The following is a description of a gene set: Human Gene Set: MIR296_3P species: Homo sapiens from publication Chen Y, Wang X (PMID 31504780) Genes predicted to be targets of miRBase v22 microRNA hsa-miR-296-3p in miRDB v6.0 with MirTarget v4 prediction scores > 80 (high confidence targets)., and this is the list of marker genes: ATP5MG, C1QTNF7, GOLGA6L10, TRPC5, AZI2, ABLIM3, ZNF28, TOMM70, ZNF493, EXPH5, PFN2, ZNF124, SLITRK2, ZNF138, MACO1, OR51E1, ITM2A, ZNF99, ADPRHL1, ZNF763 (zinc finger protein 763), STRN3, GOLGA6L4, ZNF117, LMLN, LRRTM3, TMPPE, NAV1, NCMAP, SPINT2, JOSD1, JTB, SWT1, ZNF781, ZFP90, MED14OS, ZNF629, CADPS